The following is a description of a gene set: Mouse Gene Set: REACTOME_REGULATION_OF_TP53_ACTIVITY_THROUGH_ACETYLATION studied in species Mus musculus Regulation of TP53 Activity through Acetylation, and this is the list of marker genes: Chd4, Brpf1, Rbbp4, Meaf6, Kat6a, Ing5, Mbd3, Pip4k2b (NCBI Gene Id 84507), Ing2, Rbbp7, Chd3, Gatad2b, Pip4k2c, Brd7, Akt2, Akt1, Pip4k2a, Ep300, Pip4p1, Pin1, Brd1 (NCBI Gene Id 76911), Pml, Hdac1, Mta2, Trp53, Akt3, Gatad2a, Brpf3, Map2k6